The following is a description of a gene set: Genes predicted to be targets of miRBase v22 microRNA hsa-miR-151a-3p in miRDB v6.0 with MirTarget v4 prediction scores > 80 (high confidence targets). from publication Chen Y, Wang X (PMID 31504780) Human Gene Set: MIR151A_3P studied in species Homo sapiens, and this is the list of marker genes: YTHDF3, PITPNA, MTARC2, NAMPT, NIPAL2, CLASP2, AGO2, FXR1, GFM2, MAP3K19, CASD1 (CAS1 domain containing 1), CLK1, STXBP1, ZNF326, MAGEA2B, LRCH1, NAA15, MAGEA2, AQP4, RILPL2, FAM76B, SEC63, GRM3, ME1, DCTN4, FAM120AOS, ZKSCAN4, MANEA, MAGEA1, UPP2, RPS6KA5, NPAS3, RFX3, COL25A1